Given this list of marker genes NKX2-5, ROBO1, NOTCH2 (NCBI Gene Id 55574), ZFPM1, SOX4, HECTD1, ZBTB14, ROBO2, TWIST1, HEY2, STRA6, DKK1, MTOR, SLIT2, NFATC1, ELN, TIE1, MEF2C, ACVR1, SNAI2 (NCBI Gene Id 6591), TNFRSF1B, SCX, GJA5, SLIT3, EMILIN1, AXIN2, HEYL, ROCK2, PRDM1, FGFRL1, NPPA, NOTCH1, CCN1, GATA4, MDM2, RB1, TBX20, HEY1, TGFB1, BMP4 (NCBI Gene Id 652), BMP2, MDM4, ADAMTS9, APC, BMPR2, OLFM1, RBPJ, RHOA, NOS3, FAM114A1 (NCBI Gene Id 92689), ROCK1, TBX5, ADAMTS5, TNFRSF1A, TGFBR2, ADAMTS19, SMAD2, NAGLU, SMAD6, PITX2, DLL4, PCDHA10, MATR3, BMPR1A, GATA5, PDE2A, DCHS1, JAG1, SMAD4, SNAI1, CDH11, APLNR, GATA3, SOX9, SHOX2, EFNA1, TGFB2, here is a description of the gene set: species: Homo sapiens Human Gene Set: GOBP_HEART_VALVE_DEVELOPMENT The progression of a heart valve over time, from its formation to the mature structure. A heart valve is a structure that restricts the flow of blood to different regions of the heart and forms from an endocardial cushion.